Given this list of marker genes Rpl5, Cops9, Rpl11, Dcun1d3, Cdkn2a, here is a description of the gene set: Any process that stops, prevents or reduces the frequency, rate or extent of protein neddylation. Mouse Gene Set: GOBP_NEGATIVE_REGULATION_OF_PROTEIN_NEDDYLATION species: Mus musculus